The following is a description of a gene set: from publication Abbas AR, Baldwin D, Ma Y, Ouyang W, Gurney A, Martin F, Fong S, van Lookeren Campagne M, Godowski P, Williams PM, Chan AC, Clark HF (PMID 15789058) Immune cell-specific expression is one indication of the importance of a gene's role in the immune response. In order to identify such patterns, we set out to broadly profile gene expression in a variety of immune cells. Human Gene Set: GSE22886_NAIVE_CD8_TCELL_VS_NEUTROPHIL_UP species: Homo sapiens Genes up-regulated in comparison of naive CD8 T cells versus unstimulated neutrophils., and this is the list of marker genes: YIF1A, HACD2, TMEM147, USP24, GLUD1, XBP1, IMP3, EPRS1, ADPRM, EZR, DUSP7, ZNF32, TMEM230, AUTS2, CDC23, RGS10, GZMA, EXOSC10, PRKCA, FBXW2, GANAB, RCN2, EOLA1, PSMA1, ACSL5, CD2, POP4, PSMA5, AIDA, SUPT7L, TRAF3IP3, AIFM1, MAPRE2, PCNT, TSPYL4 (TSPY like 4), TRIM44, LRIG1, DDX46, ENO2, EIF6, CYP20A1, PTPN4, PRP4K, STK39, DDX1, SMIM10L1, PRKRA, MTREX, PNMA1, SLC39A8, MPHOSPH10, MAP3K4, TPT1P8, PRELID3B, HLA-DPB1, EVL, TBL1XR1, PFKP, TUT4, DAZAP1, PPP3CB, MTR, C9orf78, TTC31, DARS1, HDDC2, YARS1, SIDT1, GCLC, TOMM70, ELP3, MAIP1, BATF, DENND2D, MGAT2, CD7, GPR171, IDH2, PJA1, ACVR1, MAL, CCDC59, APPL1, LRRC41, B4GALT3, DDX60, CRTAM, HNRNPDL, LY9, ESD, JADE2, SUCLG2, SF3A3, UBE3C, FYCO1 (NCBI Gene Id 79687), TSC22D1, ZNHIT6, ACAA2, THYN1, PIGH, EIF1AX, VTI1B, UBE3A, RNF220, PPRC1, ATP8A1, ADNP2, WDR11, SEPTIN6, ZBTB20, MPHOSPH9, TMEM14B, SMC5, DFFB, SUN2, NDUFAB1, CEP68, TMED9, HYOU1, SNRNP27, SSRP1, ANKRD10 (ankyrin repeat domain 10), FBXO21, CIAPIN1, ECHDC2, FAM3C (NCBI Gene Id 10447), INPP4A, TERF2, IL10RA, PLEKHA1, SNRPF, ATP2A2, MACF1, AVEN, SEM1, ITM2A, NMRK1, SFPQ, HMGN3, SF3B3, SCAMP3, PRF1, SRSF6, PWP1, NAA15, SPAG7, RHOH, SUCLG1, CCDC25, PAN2, SP140, RUNX3, BEX4, BUD23, RPS25, EEIG1, SNRPA, GATD3, NUCB2, CD69, AIMP1, BNIP3, POLR1D, CD3E (CD3 epsilon subunit of T-cell receptor complex), NOL7, CD81, MOAP1, RPA1, GRPEL1, BANF1, VPS26C, HSD17B10, IMP4, PRPSAP2, SUMO3, PIEZO1, LEPROTL1, TARS1, HMCES, SYPL1, MPV17, LAX1, UTP3, PPP1R16B, RGCC, TNPO2, CLNS1A, BCR, LRPPRC, SRSF7, CLEC2D, RANBP6, TUFM, TXK, RPA2, EIF2D, MCM3, NSUN5P2, TMEM106B, FAM20B